Given this list of marker genes TPO, TSHR, AIRE, PROP1, SLC35A2, ALB, POU1F1, NKX2-5, NKX2-1, TSHB, DCAF17 (NCBI Gene Id 80067), LHX3, SECISBP2, DMXL2, THRB (NCBI Gene Id 7068), PMM2, SLC5A5, PDGFRB, GNAS, ROBO1, SMARCAL1, PSMB8, MANF, IGSF1, GLIS3, DUOXA2, TBL1X, CPE, LHX4, SLC25A36, ALMS1, PLVAP, MRPS7, PRKAR1A, KCNJ18, IRS4, CDH23, FOXE1, PAX8, TG, SLC16A2, TRHR, HESX1, SMC5, IYD, OTX2, DUOX2, here is a description of the gene set: Abnormal thyroid-stimulating hormone level studied in species Homo sapiens Any deviation from the normal amount of the thyroid-stimulating hormone (TSH), which is produced by the anterior pituitary gland and stimulates the function of the thyroid gland. Human Gene Set: HP_ABNORMAL_THYROID_STIMULATING_HORMONE_LEVEL